Given this list of marker genes ZNF671, TNFRSF1B, CAMK2D, IRF2, NFX1, CD40, ALDH1A1, HLA-DPB1, TJP2, C3AR1, C1QB, HLA-DRA, ATOX1, FN1, LILRA2, CES1, IRF1, GLS, IRF7, LIMK2, SORT1, SLC8A1, SPTLC2, APOL1 (NCBI Gene Id 8542), here is a description of the gene set: from publication Scherer CA, Magness CL, Steiger KV, Poitinger ND, Caputo CM, Miner DG, Winokur PL, Klinzman D, McKee J, Pilar C, Ward PA, Gillham MH, Haulman NJ, Stapleton JT, Iadonato SP (PMID 17651872) Gene expression in human peripheral blood mononuclear cells was systematically evaluated following smallpox and yellow fever vaccination, and naturally occurring upper respiratory infection (URI). All three infections were characterized by the induction of many interferon stimulated genes, as well as enhanced expression of genes involved in proteolysis and antigen presentation. Vaccinia infection was also characterized by a distinct expression signature composed of up-regulation of monocyte response genes, with repression of genes expressed by B and T-cells. In contrast, the yellow fever host response was characterized by a suppression of ribosomal and translation factors, distinguishing this infection from vaccinia and URI. No significant URI-specific signature was observed, perhaps reflecting greater heterogeneity in the study population and etiological agents. Taken together, these data suggest that specific host gene expression signatures may be identified that distinguish one or a small number of virus agents. Human Gene Set: SCHERER_PBMC_APSV_WETVAX_AGE_18_40YO_5_TO_7DY_UP species: Homo sapiens Genes up-regulated in peripheral blood mononuclear cell (5 to 7)d vs 0d in adults (18-40) after exposure to APSV Wetvax, time point 5 to 7D